The following is a description of a gene set: Curly hair species: Homo sapiens Human Gene Set: HP_CURLY_HAIR, and this is the list of marker genes: MAP2K1, GJA1 (NCBI Gene Id 7953), SKIC3, H4C5, KRAS, BRAF, GNB2, GAN, CDK13, HRAS, RAF1, SHOC2, ST14, KRT1, SPRED2, TMEM147, AFF4, TCHH, RIPK4, DPYSL5, KRT25, SON, RIT1, HNRNPH2, CCDC47, CERT1, NRAS, MTOR, MAP2K2, EFNB1, LZTR1, USP9X, JUP, SOS1, PPP1CB, SOS2